Given this list of marker genes TAF9B, NIBAN1, WNT5A, TRIP12, NUPR1, ADH7, SH3BP5, PLSCR4, here is a description of the gene set: species: Mus musculus The reciprocal chromosomal translocation t(4;11) is correlated with infant, childhood, adult and therapy-related high-risk acute leukemia. Here, we investigated the biological effects of MLL.AF4, AF4.MLL or the combination of both reciprocal fusion proteins in a conditional in vitro cell culture model system. Several parameters like cell growth, cell cycling capacity, apoptotic behavior and growth transformation were investigated under physiological and stress conditions. Co-transfected cells displayed the highest resistance against apoptotic triggers, cell cycling capacity and loss-of-contact inhibition. These analyses were complemented by gene expression profiling experiments and specific gene signatures were established for each of the three cell lines. Interestingly, co-transfected cells strongly upregulate the homeobox gene Nanog. In combination with Oct4, the Nanog homeoprotein is steering maintenance of pluripotency and self-renewal in embryonic stem cells. Transcription of Nanog and other stem cell factors, like Oct4 and Bmi1, was verified in biopsy material of t(4;11) patient cells which express both reciprocal t(4;11) fusion genes. In conclusion, the presence of both reciprocal MLL fusion proteins confers biological properties known from t(4;11) leukemia, suggesting that each of the two fusion proteins contribute specific properties and, in combination, also synergistic effects to the leukemic phenotype. Human Gene Set: GAUSSMANN_MLL_AF4_FUSION_TARGETS_B_DN from publication Gaussmann A, Wenger T, Eberle I, Bursen A, Bracharz S, Herr I, Dingermann T, Marschalek R (PMID 17130830) Down-regulated genes from the set B (Fig. 5a): specific signature shared by cells expressing either AF4-MLL or MLL-AF4 fusion proteins.